The following is a description of a gene set: Human Gene Set: GSE3982_BASOPHIL_VS_TH1_DN Genes down-regulated in comparison of basophils versus Th1 cells. studied in species Homo sapiens In the present study we used Affymetrix oligonucleotide microarrays to produce gene transcription profiles for the major leukocyte types in humans. This comprehensive dataset enabled us to not only establish which genes were expressed in each leukocyte type, but also which genes were expressed in each subset after activation. The used of a comprehensive dataset of gene profiles from all the major human leukocyte subsets enabled a novel and powerful means for identification of genes associated with single leukocyte subsets, or different immune paradigms. from publication Jeffrey KL, Brummer T, Rolph MS, Liu SM, Callejas NA, Grumont RJ, Gillieron C, Mackay F, Grey S, Camps M, Rommel C, Gerondakis SD, Mackay CR (PMID 16474395), and this is the list of marker genes: HELLS, CHEK1 (checkpoint kinase 1), LIMA1, STK39, PNP (purine nucleoside phosphorylase), CTNNAL1, SINHCAF, LILRA6, DDOST, RAD51, ANO10, CKS2, ELOVL6 (ELOVL fatty acid elongase 6, NCBI Gene Id 79071), MRPL11, PHB1, SLC25A32, YARS1, MRPS15, IL2RA, MALT1, HMGB3, ZFPM2, SPSB1, SLAMF1, KIFBP, SFI1, POLA1, GGCT, SCNN1G, HSD17B12, TMEM223, SLC38A1, DDX10, LARP4, NASP, MYO5A, B4GALT5, ALDH18A1, DIXDC1, MTG1, GCAT, DOHH, OLA1, STMN1, PSMB2, MRPS18A, MAMLD1, MORC2, HCFC1, MRPL13, GLB1L2, KRT37, MKLN1, CENPS, HBEGF, OGFOD2, HMGA1, HSPD1, STXBP1, GLRX2, RAI14, IARS1, SH2D1A, PRMT5, NME1, DOLK, CD28, SCAND1, DPH2, PDIA5, RRP7A, AQP3, CCNJL, QDPR, CCL4 (NCBI Gene Id 6351), TUBG1, PPFIA3, PDE4D, LRIT1, SLPI, EVI2A, EEF2, RANBP1, SHQ1, CHAF1B, DDIT4, SPAG5, SNRPF, AURKA, PPFIA1, GRK3, NQO1, BUB1B, GFOD3P, ADRM1, OGFOD3, RPS6KB2, WIZ, ELOVL4, PAICS, CBR3, CDC37, CC2D1A, CAST, XRCC2, SPRY1, PSMB5, BLM, MLLT11, NUP37, BFAR, HMGXB3, MRPL4, BRD3OS, RANGRF, DHODH, ACSL3, TOMM40, SAC3D1, PTGIR, RWDD2B, YWHAH, FNDC3B, MRPL39, HS3ST2, TMED3, SACS, MAGEC2, OTULINL, TCERG1, MOCS3, PPIF, DNAJC9, SLC17A1, MRC2, PLA2G4C (NCBI Gene Id 8605), MAPK8, PPP1R2, PRPF19, MRTO4, ILF3, SQOR, SMCO4 (single-pass membrane protein with coiled-coil domains 4), MSH2, CA5BP1, DOCK4, MFHAS1, PSD4, RRM1 (ribonucleotide reductase catalytic subunit M1), CDC123, CHL1, APOBEC3G, RSRC1, NETO2, NUDCD3, C1orf216, ABCF2, CHEK2, AARS1, ENO1, HIBCH, MTHFD1, NRBP1, ARL6IP1, IKBKE, AKR1B1 (aldo-keto reductase family 1 member B), CTSH, GRM3, MRTFB, LRRC20, EIF5A, CCNE2, POLR2J2, GPN2, PRKAR2A, MICB, CYP11B1, MSMO1, PHACTR4, SYTL2, MAGIX, GOLT1B, RRP9, APBB3, UBFD1, TESK1, GGH, MIS18A, SNTB2, SLC2A5, PLEKHG6 (pleckstrin homology and RhoGEF domain containing G6), TMEM97, ZWILCH, CDR2, PSMC4, IFT56, NEK2 (NCBI Gene Id 4751), DCPS, CBR1 (carbonyl reductase 1)